The following is a description of a gene set: Human Gene Set: GOCC_NEURONAL_RIBONUCLEOPROTEIN_GRANULE A ribonucleoprotein complex that is found in the cytoplasm of axons and dendrites, and transports translationally silenced mRNAs to dendritic synapses, where they are released and translated in response to specific exogenous stimuli. species: Homo sapiens, and this is the list of marker genes: PQBP1, ARC, UHMK1, HNRNPAB, FMR1, EIF4EBP2